Given this list of marker genes CD33, G0S2, ADGRA2, LAMB3, SGCD, SIGLEC15, PID1, CCL24, CD93, VNN1, HTR7, here is a description of the gene set: studied in species Homo sapiens from publication Haralambieva IH, Zimmermann MT, Ovsyannikova IG, Grill DE, Oberg AL, Kennedy RB, Poland GA (PMID 27529750) Human Gene Set: HARALAMBIEVA_PBMC_M_M_R_II_AGE_11_22YO_VACCINATED_VS_UNVACCINATED_LOW_ANTIBODY_RESPONDERS_TO_TREATMENT_7YR_DN Genes down-regulated in peripheral blood mononuclear cell vaccinated vs unvaccinated in adolescent/young adults (11-22) (low antibody responders to treatment) after exposure to M-M-R II, time point 7Y BACKGROUND: There are insufficient system-wide transcriptomic (or other) data that help explain the observed inter-individual variability in antibody titers after measles vaccination in otherwise healthy individuals. METHODS: We performed a transcriptome(mRNA-Seq)-profiling study after in vitro viral stimulation of PBMCs from 30 measles vaccine recipients, selected from a cohort of 764 schoolchildren, based on the highest and lowest antibody titers. We used regression and network biology modeling to define markers associated with neutralizing antibody response. RESULTS: We identified 39 differentially expressed genes that demonstrate significant differences between the high and low antibody responder groups (p-value <= 0.0002, q-value <= 0.092), including the top gene CD93 (p < 1.0E-13, q < 1.0E-09), encoding a receptor required for antigen-driven B-cell differentiation, maintenance of immunoglobulin production and preservation of plasma cells in the bone marrow. Network biology modeling highlighted plasma cell survival (CD93, IL6, CXCL12), chemokine/cytokine activity and cell-cell communication/adhesion/migration as biological processes associated with the observed differential response in the two responder groups. CONCLUSION: We identified genes and pathways that explain in part, and are associated with, neutralizing antibody titers after measles vaccination. This new knowledge could assist in the identification of biomarkers and predictive signatures of protective immunity that may be useful in the design of new vaccine candidates and in clinical studies.